The following is a description of a gene set: Human Gene Set: GOBP_LIPID_BIOSYNTHETIC_PROCESS The chemical reactions and pathways resulting in the formation of lipids, compounds soluble in an organic solvent but not, or sparingly, in an aqueous solvent. species: Homo sapiens, and this is the list of marker genes: DAGLA, IP6K3, MTOR, TSPO, PIP4K2B, PNLIP, PLD2, PTGES3, LCAT, ACER1, SLC45A3, EFR3A, HTD2, ACP6, CBR1, ELOVL4, ACSL3, PRKAA1, PLA2G4C, MIR766, ALDH1A2, ELOVL2, ELOVL7, ST6GALNAC3, CD74, BPNT2, AVIL, SAMD8, INPP4A, PIGN, SDR42E2, ABHD3, AGPS, PISD, A4GALT (NCBI Gene Id 53947), DPM2, ABCC1, PRKD1, PBX1, MED1, AGK, GLT6D1, CRH, ABCG1, TMEM150A, FBXW7, PIGY, MIR342, PRKD3, ATP1A1, ASXL3, APOC2, SERINC4, PIGL, CYP7B1, KLHL25, DHH, QKI, SIRT2, PMVK, CHKA, UVRAG, ANGPTL4, IP6K2, PRKCD, ITPKB, GPAT3, BCO1, OCRL, ST8SIA3, PNPLA1, CYP7A1, ACOT7, MIR30C1, HTR2A, WDTC1, IDH1, DEGS1, FIG4, INPP5J, GPAT4, PITPNM1, B4GALNT2, ORMDL2, LHCGR, PGAP3, ACLY, ACSM2B, ABCG4, PTPRQ, GBA1, TMEM68, EDN2, ABCD2, ST3GAL3, HMGCLL1, PIGK, PLCG2, PRKAB1, RDH10 (retinol dehydrogenase 10), SPTSSB, SLC44A5, APOA1, PIGW, CYP8B1, SIK1, HMGCL, SQLE, HSD17B3, GSTM4, LIPG, ST3GAL6, APOC3 (apolipoprotein C3), DGKA, THNSL2, ALOX12, PIGO, ACSBG1, FADS2B, PDGFA, KPNB1, THRSP, CYP2R1, ABCG2, NR0B1, SORBS1, CERS2, APOB, LPCAT1, TMEM135, MBOAT2, PCYT2, MFSD2B, GGTLC3, ST8SIA4, INPP5D, GGT5 (NCBI Gene Id 2687), PTPMT1, CERS4, IP6K1, ATG14, ASAH1, PLA2G4F, PECR (NCBI Gene Id 55825), GGT7, CWH43, PIK3CG, KDSR, ALOX12B, CYP27A1, AWAT1, PGAP2, ACSF3, CERS6, PIK3C2A, MBTPS2, PIGQ, ISYNA1, CERS5, PRKG1, ELOVL3, IFNG, DHRS9 (dehydrogenase/reductase 9), SPTLC2, RICTOR, FGF1, HSD17B7, MID1IP1 (NCBI Gene Id 58526), PIK3C3, CYP2C9, GSTM2, PIP5K1C, PI4KAP2, GGPS1, ENPP7, SCP2, ABO, FABP5, MIR132, APOA4, CNEP1R1, TM7SF2, DGKZ, ASAH2, FAR1 (NCBI Gene Id 84188), PRKAG2, PIP4K2C, ACSBG2 (NCBI Gene Id 81616), CYP24A1, ALDH8A1, C20orf173, TAMM41, ABCD1, SERAC1, GPR146, DGKB, MIR33A, TTC7A, DHCR7, PIK3R1 (phosphoinositide-3-kinase regulatory subunit 1), AJUBA, DCAF5, GAL3ST3, HMGCS2, PLP1, EHHADH, PDSS1 (NCBI Gene Id 23590), HSD17B13, OGT, ABCA8, STARD3, PIGB, HYCC1, AVPR1A, PCYT1A, MIR29B1, PIP5K1A, FA2H, C3, CDIPT, HYCC2, DOLK, LHB, PCYT1B, PEX7, PLD1, LSS, B4GALT6, SEC14L2, SCARB1, ST3GAL2, DGKI, INPP5K, PNPLA2, EGR1, CYP27B1, EFR3B, PI4KB, PI4K2A, DGAT2L6, PIK3CA, FUT6, SH3GLB1, PIGX, DDX20, MIR204, CEACAM1, PNPLA8, CYP11B2, SPTLC3, ACSM3, CREB1, CERS3, MLXIPL, FAXDC2, SPTSSA, H6PD, CTHRC1, PITPNM2, ST8SIA5, OLAH, ST8SIA2, BECN1, MFSD2A, PIK3C2B, ACSS3, SMPD2, RPTOR, ST3GAL5, ERG28, IGFBP7, CHKB, PRKAG1, FUT2, AKR1B15, DGKH, AACS, ATM, PDSS2, OXSM, CYP4F22, SERPINA12, B4GALT3, PIGS, PIGP, ACSL1, MOGAT3, PGS1, PIBF1, NR1D1, TRIB3, FDFT1, CRLS1, TPTE2, GSTM1, DGAT1, LARGE1 (NCBI Gene Id 9215), PNLIPRP2, PRKAA2, CLN3, GFI1, FGFR4, LIPA, HDHD5, APOC1, CERKL, AGPAT4, PIP5KL1, NR5A2, AGMO, SERINC1, B3GALNT1, CREBL2, DHCR24, ACSM6, ERLIN2, ACSM5, DAGLB, LPL, PPM1L, NR5A1 (NCBI Gene Id 2516), SMPD4, DGAT2, PTDSS1, REST, MBOAT7, TECR, SERPINA6, KAT5, CYP1A1, NSDHL, ADGRF5, ST6GALNAC4, MIR206, GNAI1, MTM1, PIGT, AQP8, PCK2, ACACA, CERS1, PPT1, DHDDS, B4GALNT1, ARMC5, MIR182, BMX, SDR42E1, PRLR, CFTR, ZBTB20, OSBP, PLCE1, MVD, MLST8, ETNK2, CYB5R3, CDS2, PTGES2, ACSM4, ZNF750, HPGDS, CYP11A1, AGPAT3, APOE, GAL3ST2, CYP2C8, ERLIN1, PTGS1, IMPA1, HTR2B, ST3GAL1, ALOX15B, CYP2E1, FABP3, PIK3CB, EDN1, CERK, MIR98, PTGS2, ST6GALNAC6, LPIN1, ACAT1, MTMR2, PIKFYVE, FASN, CLCN2, B3GALT4, P2RX7 (NCBI Gene Id 5027), ACOX1, NR1H2, PIK3C2G (phosphatidylinositol-4-phosphate 3-kinase catalytic subunit type 2 gamma), GGT6, HMGCR, MTMR4, HMGCS1, GPAM, TNF, INPPL1, HSD17B6, TTC7B, MALRD1, PLIN5, ACBD3, PIGU, BGLAP, PCK1 (NCBI Gene Id 5105), PIGM, ACSS2, MTMR14, FLVCR1, GPIHBP1, LIPI, PTDSS2, SACM1L, HINT2, ACADVL, GBGT1 (globoside alpha-1,3-N-acetylgalactosaminyltransferase 1 (FORS blood group)), DGKK, PTGDS, ABHD8, ALOXE3, PIPSL, BPNT1, SPTLC1, ACOT4, HSD17B4 (hydroxysteroid 17-beta dehydrogenase 4), SLC35C1 (solute carrier family 35 member C1), AGPAT5, PLA2G3, ABHD2 (NCBI Gene Id 654057), GPX4, DHRSX, SLC44A1, LIAS, TECRL, VAC14, SLC30A5, ADM, INSIG2, CYB5R1, MTMR6, SELENOI, SMPD1, PIGZ, PLA2G15, UGT8, CACNA1H, PRKAB2, ACACB, PIGA, ACER2, VAPA, MTMR3, HACD1, CHAT (choline O-acetyltransferase), LBR, DGKG, PRKAG3 (NCBI Gene Id 53632), GPER1, SRD5A1, ABCD3, CYB5R2, ITPKC, B4GALT4, ACOT8, HSD3B2, LPCAT3, MIR9-1, PITPNM3, LEP, GAL3ST1, FADS3, ACSM2A, SC5D, ELOVL6, PRXL2B, PLA2G1B, RAB38, PLAAT3, B4GALT5, PIK3R3, CES1, ITPKA, GGTLC1, PNPLA3, LPGAT1, PDK4, ACSL4, DKKL1, ETNK1, RDH8, SPHK1, FADS1, INPP1, DECR2, AKR1B1, HSD17B1, PTEN, SERINC5, CH25H, PIK3CD, SYNJ2, PPARA, FDPS, ABHD4, MAPK1, P2RX1, AKR1C3, FITM1, AGPAT1, SPNS2, GBA2, STARD4, NR1H4, HACD3, ELOVL1, HTR2C, GPRC6A, NR3C1, GGT3P, MTMR7, PIGV, CGA, FUT9, INPP4B, AGPAT2, DEGS2, HSD17B8, SNAI1, SCAP, TBXAS1, SLC44A3, LPCAT4, PPT2, LPIN3, SLC44A2, RPE65, PNLIPRP3, MCAT, MECR, HACD2, RBP1, SRD5A2, AWAT2, DOLPP1, GNPAT, LIPC, GAL3ST4 (galactose-3-O-sulfotransferase 4), ALDH1A3, HSD17B12, NDUFAB1 (NCBI Gene Id 4706), CAPN2, GK, PIGC, INSIG1, SLC44A4, PGAP4, LCLAT1, FITM2, FADS2, MIF, PIP5K1B, TLCD3B, ARV1, CTDNEP1, SREBF2 (sterol regulatory element binding transcription factor 2), CYP1A2, HSD17B11, NUS1, INS, GSTP1, CSNK1G2, NR1H3, SMG1, PAQR3, GGCX, TMEM38B, ST8SIA6, NFKB1, SIRT4, PIGF, CYP2D6, ABCA3, DGKQ, ELOVL5, HSD3B1, BRCA1, KAT2B, ST8SIA1, EIF6, ACSS1, CEPT1, PAQR4, MBTPS1, FADS6, BMP2, DHRS7B, BMP6, SRD5A3, MPPE1, SH3YL1, LPCAT2, PIGG, PNLIPRP1, IDI1, UBR4, PLA2G4A, PDGFB, SCD, INPP5F, PLA2G10, ABCA2, SGMS2, MLYCD, SIRT1, DPM1, B3GALT2, PEDS1, LIPH, GPAT2, PRMT3, MVK, PIGH, PRKACA (NCBI Gene Id 5566), PGAP1, PLA2G6, ABHD6, CCDC3, FUT1, IMPA2, NPC1L1, PPARD, PIK3R4, SCCPDH, GGT2P, SPHK2, DPM3, MSMO1, PIP4K2A, PTGIS, GPLD1, FDXR, CHP1, MIR1-1, PLSCR1, GGTLC2, FUT4, SLC27A1, LTC4S, LPIN2, CYP3A4, APOA2, CBR4, MBOAT1, INPP5E, GPAA1, DAB2, HSD3B7, MOGAT2, HACD4, ST6GALNAC5, PRKD2, B3GALT1, CYP51A1, CCN1, XBP1, FDX1, ALOX15, SLC27A2, ABHD1, AKT1, PTGES, INHBA, ORMDL1, ORMDL3, CLN8, SLC27A5, PEMT, PDE8B, ALOX5, ACADL (NCBI Gene Id 33), GCDH, SYNJ1, DGKE, CYP17A1, UGCG, ACSM1, ACSL5 (NCBI Gene Id 51703), COQ2, HSD17B2, PRPF19 (pre-mRNA processing factor 19), MIR548P, MGLL, PAM, TMX1 (NCBI Gene Id 81542), HEXB (NCBI Gene Id 3074), FAR2, ST3GAL4, G6PD, CYP11B1, CDS1, DGKD, ACER3, C7orf50, PLPP6, FSHB, SCD5, MTMR1, ACAA2, WNT4, BCKDK, SNAI2, MIR96, BMP5, TREX1, ABHD5, PROX1, CYP21A2, DKK3, SGMS1, POR, EBP, SIRT3, DHRS11 (NCBI Gene Id 79154), A3GALT2, GGT1, PI4KA, TM9SF2, ACSL6, GIP, CYP3A7, PI4K2B, AVP, CHPT1, FGF19, STAR, MIR185, SREBF1, MOGAT1, IDI2, B3GNT5, APOA5, GGTA1, IL1B, LDLR, CRPPA, CYP19A1, PLAA